Given this list of marker genes Evc, Gnb1, Septin2, Mxra8, Gucy2e, Rom1, Cltb, Bbs4, Tspear, Adcy3, Eps15, Umod, Iqce, Evc2, Gpr37l1, Drd2, Bbs5, Ceacam1, Slc9c1, Ffar4, Smo, Pkd2, Txndc15, Drd5, Phlpp2, Pde6a, Micall1, Ift46, Bbs1, Rdh11, Prcd, Shank2, Ehd3 (NCBI Gene Id 57440), Cnga2, Tmem231, Arl6, Mchr1, Tmem67 (NCBI Gene Id 76678), Arl13b, Tas2r108, Pde6b, Pkd1l1, Bbs7, Gucy2d, Cys1, Gpr161, Rab8a, Snap29, Ehd1, Gpr88, Pkd2l1, Gpr157, Shank3 (SH3 and multiple ankyrin repeat domains 3), Sstr3, Pde6h, Pde6g, Prom1, Drd1, Prph, Cdhr1, Prom2, Efcab7, Tmem17, Cnga1, Cask, Mosmo, Cd24a, Cnga4, Arl13a, Bbs2, Rho, Gpi1, Bbip1, Ttc8, Scnn1a, Bbs9, here is a description of the gene set: Mouse Gene Set: GOCC_CILIARY_MEMBRANE species: Mus musculus The portion of the plasma membrane surrounding a cilium.